Given this list of marker genes Srp14, Srp54b, Srp54c, Srp68, Srp54a, here is a description of the gene set: Mouse Gene Set: GOMF_ENDOPLASMIC_RETICULUM_SIGNAL_PEPTIDE_BINDING Binding to an endoplasmic reticulum signal peptide, a specific peptide sequence that acts as a signal to localize the protein within the endoplasmic reticulum. species: Mus musculus